The following is a description of a gene set: Transforming growth factor beta (TGF-beta) and platelet-derived growth factor A (PDGFAlpha) play a central role in tissue morphogenesis and repair, but their interplay remain poorly understood. The nuclear factor I C (NFI-C) transcription factor has been implicated in TGF-beta signaling, extracellular matrix deposition, and skin appendage pathologies, but a potential role in skin morphogenesis or healing had not been assessed. To evaluate this possibility, we performed a global gene expression analysis in NFI-C(-/-) and wild-type embryonic primary murine fibroblasts. This indicated that NFI-C acts mostly to repress gene expression in response to TGF-beta1. Misregulated genes were prominently overrepresented by regulators of connective tissue inflammation and repair. In vivo skin healing revealed a faster inflammatory stage and wound closure in NFI-C(-/-) mice. Expression of PDGFA and PDGF-receptor alpha were increased in wounds of NFI-C(-/-) mice, explaining the early recruitment of macrophages and fibroblasts. Differentiation of fibroblasts to contractile myofibroblasts was also elevated, providing a rationale for faster wound closure. Taken together with the role of TGF-beta in myofibroblast differentiation, our results imply a central role of NFI-C in the interplay of the two signaling pathways and in regulation of the progression of tissue regeneration. Genes up-regulated after 10 h of TGFB1 stimulation in MEF cells (embryonic fibroblast) with NFIC knockout vs wild type MEFs. Mouse Gene Set: PLASARI_TGFB1_SIGNALING_VIA_NFIC_10HR_UP studied in species Mus musculus from publication Plasari G, Calabrese A, Dusserre Y, Gronostajski RM, McNair A, Michalik L, Mermod N (PMID 19752192), and this is the list of marker genes: Plscr1, Slmap, Epha7, Fgf7, Clca3a1, Celsr3, Ano1, Unc5c, Plekhh2, Kdm5a, Nrn1, Pcsk5, Gpm6b, Parm1, Fas (Fas cell surface death receptor), Csf1, Col2a1, Chodl, Steap2, Nnat, Xrn1, Plscr2, Myh11, F3, Enpp5, Gvin1, Itga1, Stk26, Sparcl1, Pierce1, Adgrg6, Aif1l, Arc, Il18rap, Cyp2j6, Mpzl2, Ifi44, Pax1, Serpina3g, Nrep, Gjb4, Orai2, Rgs5, Tmtc4, Nfib (nuclear factor I/B), Sema3c, Irag1, C1s1 (NCBI Gene Id 50908), Vcam1, Tbx3, Olr1, Epha4, Rgs4, Pdk4, Il1rap, Cd38, Perp, Cpxm1, Rictor